The following is a description of a gene set: Any process that stops, prevents or reduces the frequency, rate or extent of reactive oxygen species biosynthetic process. Mouse Gene Set: GOBP_NEGATIVE_REGULATION_OF_REACTIVE_OXYGEN_SPECIES_BIOSYNTHETIC_PROCESS studied in species Mus musculus, and this is the list of marker genes: Abcb7, Ptgr1, Ppara, Ndufc2, Rhoa, Hbp1, Sirt1, Fyn, Mpv17l, Ins2 (NCBI Gene Id 16334), Hspd1, Adcy10, Abcd1, Ctns, Stat3, Prkn, Hif1a, Cflar, Mfn2, Abcd2, Ins1, Park7, Coa8